The following is a description of a gene set: species: Homo sapiens Purpura Purpura (from Latin: purpura, meaning purple) is the appearance of red or purple discolorations on the skin that do not blanch on applying pressure. They are caused by bleeding underneath the skin. This term refers to an abnormally increased susceptibility to developing purpura. Purpura are larger than petechiae. Human Gene Set: HP_PURPURA, and this is the list of marker genes: GFI1B, F13A1, DPP9, TBX1, TNFRSF13B, HPS6, COL5A1, CR2, USP18, TP53, SEC24C, GP1BB, ITGB3, HIRA, HLA-DPB1, PRKAR1A, COL1A1, ARL6IP6, C2, NFKB2, NAGA, COMT, CLCN7, USP8, ITGA2B, PRF1, GNA11, FIP1L1, F13B, JAK2, PROS1, CALR, STXBP2, TBL1XR1, HCK, GBA1, RUNX1, OCLN, NR3C1, RAB27A, JMJD1C, WAS, TERC, DCLRE1B, ETV6, CFH, PTPN22, GP9, HOXA11, ICOS, ADA2, SH2B3, NEU1, ZBTB16, NLRP3, STX11, COL5A2, PLCG1, TET2, LCP2, PRTN3, SAMD9, FCGR2C, F2, BCOR, GATA1, CD109, CDH23, CD19, APOE, PTPRJ, IFNG, F8, GNE, LYZ, MYD88 (NCBI Gene Id 4615, MYD88 innate immune signal transduction adaptor), BRAF, NUMA1, TBXA2R, P2RY12, ORAI1, ACP5, CHST14, HPS1, ETHE1, NABP1, PEPD, NPM1, GNA14 (G protein subunit alpha 14), IRF2BP2, WIPF1, HLA-DPA1 (major histocompatibility complex, class II, DP alpha 1), SBDS (SBDS ribosome maturation factor), COL3A1, FYB1, PML, TNFSF12, STIM1, MS4A1, FUCA1, LYN, FERMT3, RREB1, TFR2, GIMAP5, CASP10, MVK, F9, CFHR1, TERT, ITGA2, AIP, CFHR3, MPL, C4A, UFD1, UNC13D, GP6, TNFRSF13C, NFKB1 (nuclear factor kappa B subunit 1), ATRX, USP48, ARVCF (ARVCF delta catenin family member), CTLA4, TREX1 (NCBI Gene Id 82474), PROC, STAT5B, STAT3, RARA, GP1BA, CD81, GGCX